Given this list of marker genes Smc5, Zfp953, Filip1l, Amy2a4, Baat, Lclat1, Foxf2, Mid1, Aff1, Lrrc32, Fbxw2, Slc24a5, Zfp563, Mpped2, Mark1, Zbtb39 (NCBI Gene Id 320080), Slc41a2, Rabgap1 (RAB GTPase activating protein 1), Tmem200c, Ccl11, Inpp4a, Pabpc2, Or5d38, Cdh4, Fyco1, Zfp780b, Amy2a3, Tmc1, Ttc9, Clec4g, Txlnb, Nhsl2, Vwa7, Abcd3, Mylk4, Rdh13, Urod, Rimklb, Zdhhc15, Rab28, Ano5, Glt8d2, Zfp458, Sh3bgrl, Sacm1l, Oacyl, Prdx3, P2ry10, Bloc1s2, Zfp811, Epm2aip1, Eef2k, Clock, Zxdb, Tfrc, Cstf3, Igdcc4, Gnrhr, Larp1b (La ribonucleoprotein 1B), Jam2, Col25a1, Pced1a, Methig1, Gsap, Ercc4 (NCBI Gene Id 50505), Fam168a, Kcmf1, Havcr2, Amy2a2, Rictor, Elfn1, Nlrp2, Fkbp7, Zfp68, Cers2, Ranbp9, Ppl, Gbp7, Homer1, Zfp781b, Myot, B3gnt9, Gpc6, Eral1, Smurf1, Celf3, Kcnma1, here is a description of the gene set: studied in species Mus musculus Mouse Gene Set: MIR_804 from publication Chen Y, Wang X (PMID 31504780) Genes predicted to be targets of miRBase v22 microRNA mmu_miR_804 in miRDB v6.0 with MirTarget v4 prediction scores > 80 (high confidence targets).